The following is a description of a gene set: Human Gene Set: HP_NARROW_FOOT A foot for which the measured width is below the 5th centile for age; or, a foot that appears disproportionately narrow for its length. species: Homo sapiens Narrow foot, and this is the list of marker genes: ADK (NCBI Gene Id 132), TCF4, SCARF2, VPS13B, PQBP1, FBN1